The following is a description of a gene set: species: Homo sapiens Goals/objectives: to identify various gene expression in B cell subsets derived from human PBMC and cord blood from publication Suryani S, Fulcher DA, Santner-Nanan B, Nanan R, Wong M, Shaw PJ, Gibson J, Williams A, Tangye SG (PMID 19965666) Human Gene Set: GSE17186_NAIVE_VS_CD21HIGH_TRANSITIONAL_BCELL_CORD_BLOOD_DN Genes down-regulated in B lymphocytes from cord blood: naïve versus transitional CR2 high., and this is the list of marker genes: SNHG17, JADE2, NR6A1, FAM3C, ARAP2, S100A10, ADAD2, B4GALT1 (beta-1,4-galactosyltransferase 1), RFFL, S1PR4, TNIP1, POLR1B, MFSD9, EVL, SMAD7 (SMAD family member 7), ARHGEF1, IDNK, ADAMTS6, SMC4, POLR3GL, LBP, IGIP, PSTK, RPSA, FAM241A, ADI1, TMEM241, PPP2R5A, ELK4, CARNS1, ZNF280C, NEU1, CYP4F12 (NCBI Gene Id 66002), STK10, RASSF2, AXIN2, ZNF571, LPP-AS2, NOP10, CBX4, RHOF, BTBD6 (NCBI Gene Id 90135), PHF21A, RP9, FGF11, AKAP12, ARHGAP45, FSD2, RUNDC3B, IL6ST, ZFP1, RPS7, DDX6, BCL9L, DAND5 (NCBI Gene Id 199699), USP24, GPAM, SESN3, SKI, SMPD5, C8orf58, TPO, RNF2, SLFN12L, UBE3D, MDC1, ABL2, TPCN1, DGKZ, LEPROTL1, PAIP2, SMAD3, JAK1, EXD2, MLLT6, MAT2B, PCSK4, CD7, AMPD1, RCL1, GJD4, TMLHE, KIF1B, KCNMB4, TPP1, KCNC3, FAM8A1, SMAP2, CNP, EMG1, POU2F2, CDKAL1 (CDK5 regulatory subunit associated protein 1 like 1), SLAMF1, IGHM, DMRTA1, ARFRP1, KDM4B, RCCD1, DOCK2, CBR1, BCDIN3D, RAP1B, CD37, SLC16A10, LY6K, ADGRG3, METTL23, TTC28, SLC16A1, B3GNT2, SLC20A1, CDC14B, HS3ST3B1, DIAPH1, GBP2, ARHGDIG, BACE1, GAB3, MYO7A, PUS7, SIAH1, ARL4D, ARL2BP, ART4, AFP, PADI1, KRBA1, RPS3A, SLC25A53, RARG, SYTL2, TP53I11, ABI3, NCKAP1, CDKN2D, PSENEN, CACNA2D4, IQCC, TMCO4, SLC39A4, ESYT2, ZNF354C (NCBI Gene Id 30832), LGALS1, AP3S2, KLK8, TUT4, DNAJC15, GCFC2, GARIN3, RPS8, PPP3CC, MINDY1, HVCN1, RAP2B, P3H4, GALNT6, ZNF260 (zinc finger protein 260), RNF144A, LTA, TMEM80, FASTK, SYT17, CEP97, STING1 (NCBI Gene Id 340061), AGTR2, AFMID, CHST10, NEURL2, CLSTN1, PARD6G, CTPS2, DENND4C, MRM3, EFEMP2, SYDE2, MIF, RPL38, RNF138, ZNF2, SPICE1, RAB37, ZAP70, CPLANE1, RNF38, CD5, TUBA4A, PLAUR, MZB1, TREML2, PUS7L, MYBPC1, BZW2, NSUN6, BCL7A, ADGRL1 (NCBI Gene Id 79732), TRMT112, ASB1, TBC1D12, NPM1